Given this list of marker genes TNFRSF11B, S1PR1, NFIL3, TOPBP1, CD86, LAD1, GPR171, POLR2E, CD200, TRADD, CTNNA1 (NCBI Gene Id 619480), LGALS9, JAK1, TRAFD1, PLAGL1, FOXO1, ANXA3, STK39, HLA-DPB1, GTF2E2, LY75, FERMT2, COL14A1, HLA-DRB3, IL4R, SYNGR3, NID1, MCM5, IGFBP4, AOC1, TFRC, ATF3, PRKAR2B, TRIP10, GRSF1, SEMA7A, TCF3, ROCK2, TNFSF4, TNFRSF11A, ALOX15B, MMD, CX3CL1, PIAS3, KIF2A (NCBI Gene Id 3796), SOCS2, MGLL, ALDH2, MUC1, N4BP2L1, ARID5A, IGF1R, FGF9, STAT5A, ENPP4, DEPP1, CASP3, UGCG, TUBB2A, FLT3, CLC, STAT3, CAPG, here is a description of the gene set: from publication Lindstedt M, Johansson-Lindbom B, Borrebaeck CA (PMID 12356685) Maturation of monocyte-derived dendritic cells (DC) in response to inflammatory stimuli: genes up-regulated only at 48 hr after the stimulation (cluster C). species: Homo sapiens Maturation of dendritic cells (DC) serves a deterministic role in the link between innate and adaptive immunity, constituting a checkpoint with regard to whether responses from the lymphocyte compartment shall be raised and what class of response is needed to protect the host against invading pathogens. Since DC have not been shown to possess mechanisms such as gene recombination or somatic mutation for generating a diverse repertoire of antigen-recognition receptors, it is unlikely that these leukocytes can intrinsically respond to all conceivable molecules present in our environment. In the present study, we have therefore determined how mediators of the inflammatory response regulate global gene transcription in DC. The data represent an extensive and time-ordered reprogramming of the DC during their course of maturation, involving genes encoding proteins that regulate responses of both innate cells and lymphocytes. This transcriptional reorganization may reflect the effect of in vivo released inflammatory mediators induced by endogenous or pathogenic stimulation. Human Gene Set: LINDSTEDT_DENDRITIC_CELL_MATURATION_C